Given this list of marker genes AKT1, TP53, SLC22A18, COL14A1, SFTPC, GPC3, ZNRF3, ERBB2, SLCO2A1, SPRED1, DIS3L2, PRKN, PDGFRB (NCBI Gene Id 5159), LMNA, FASLG, TERT, CDKN2A, DICER1, TRIM28, KEAP1, IFNG, BRAF, APC2, STK11, CTNNB1, PIK3CA, MBTPS2, IRF1, NAB2, POU6F2, CHEK2, PERP, NDUFAF6, NSD1, COL4A6, ERCC6, MDM2, MAP3K8, PRKAR1A, AAGAB, KRAS, TRIP13, TRPV3, ZFTA, WT1, MUC5B, PPP2R1B, SFTPA2, BAP1, HPGD, EWSR1, WRN, REST, H19, TSC1, RB1, EGFR, CASP8, STAT6, NOTCH3 (notch receptor 3), CYP2A6, BRCA2, COL4A5, TSC2, here is a description of the gene set: Tumor of the lung. species: Homo sapiens Human Gene Set: HP_NEOPLASM_OF_THE_LUNG Neoplasm of the lung